The following is a description of a gene set: Human Gene Set: MIR16_2_3P from publication Chen Y, Wang X (PMID 31504780) studied in species Homo sapiens Genes predicted to be targets of miRBase v22 microRNA hsa-miR-16-2-3p in miRDB v6.0 with MirTarget v4 prediction scores > 80 (high confidence targets)., and this is the list of marker genes: SPOPL, UBE2B, SHQ1, TMBIM4, KHDC4, NEXMIF, RAI14, MBD5 (NCBI Gene Id 55777), MIER3, SP8 (NCBI Gene Id 378050), CNTNAP3, MOB1B, CMTM7, RC3H1, RPE, OBI1, ZNF746 (zinc finger protein 746), SLC44A5, MTHFD2L, UBE2I, CLASP2, ERAP1, MTARC2, RAB6B, RBL1 (NCBI Gene Id 5933), C16orf87 (NCBI Gene Id 388272), PTPN13 (protein tyrosine phosphatase non-receptor type 13), C18orf54, ZNF280D, NGLY1, TSPAN19, FAM181A, TDG, ZNF41, DYNLT2B, COL11A1, LARGE1, CFL2, BCHE, PCGF3, TUBB, USP16, TLK1, VDAC1, MTF2, NAT2, PLCXD3, PLAUR, PALS1, THSD7B (thrombospondin type 1 domain containing 7B), SPRED1, KIAA0408, INPP1, MACIR, ZNF107, TMED7, AP4E1, ZNF273 (NCBI Gene Id 90816), KERA, PLAGL1, CHIC1, OR2L13, BTG3, SDK2, OMA1 (OMA1 zinc metallopeptidase), DCAF8L1, HNRNPA0, CCDC141, SNRK, FGF14, ABCE1, NAB1, PDLIM5, GINS1, BTBD8, BROX, ZNF236, DSTYK, CILK1, NCAM2, AGL, OLA1, RGS2, MEI4, ACP1, RNF44, CBLN2, RBFOX1, VPS50, MME, WNT5A, KCNMB2, ADCYAP1, CTNND2, ZCCHC10, DPY19L4, ATP2C1, ITGB8, B2M, SGIP1, DENND1B, CCDC82, RAB6A, CHML, PRMT3, TMLHE, NEGR1 (NCBI Gene Id 257194), PBRM1, ATP6V1C2, ATP7A, NETO1, UFL1, PRKG1, PURA, PRLR, ZNF569, PTER, FSD1L, CDK1, ZNF254, ETF1, IRF6, CUL2, CTTNBP2, ZNF99, RORA, FBXO28, RAB1A, RGS5, KLF2, CDH9, MAP10, ZFP36, PPP4R4, SLC2A13, MIPOL1, MFSD14B, ZNF678, TMEM161B, CPEB2, CLTC, ANKRD13C, FGL2, PRKAA1, TBC1D12, CLOCK, PSMA8, CNTNAP3B, HAND2, CCN2, PAFAH1B1, INTU, TUBB2B, ZNF117, IDI1, KRTAP4-5, PSMC6, NOVA1, SEPSECS, COMMD8, CFAP65, CADM2, PTPN12, COG6, ATAD1, SIN3B (NCBI Gene Id 23309), HYCC2, MTCL3, ACOX1, CNTN3, PLPPR4, FAM111A, DIP2B, NBEAL1, CNR1, MLLT11, GPATCH2, BAHCC1, SOAT1, BCOR, RAP1A, RPP30, TNPO1, TCP1, ID1, ANXA7, ZNF699, THAP9, ZFP30, IFIT2, HIRA, RGMB, TSHZ1, RAB6D, ZNF681, DCUN1D5, ALDOB, CNTN4, CDK17, KDM7A, NFYB, PIAS2, CD200, ZFX, RDM1, CCT6A, ZNF714, RB1CC1, ARFGEF1, IYD (iodotyrosine deiodinase), GABRG1, MTMR6, PEX5L, TENT4A, RCN2, FRK, BBS10, AZIN1 (antizyme inhibitor 1), PI4K2B (phosphatidylinositol 4-kinase type 2 beta), LLGL1, STRN, GALNT1, PREX2, MARCHF6, FMNL2 (formin like 2), ACER3, IPO7, SCN2A, FAM91A1, COMMD3-BMI1, PLAG1, CDC42BPB, ARAP2